Given this list of marker genes POLR2C, POLR2J, POLR2F, POLR2A, POLR2H, PTBP1, HNRNPA1, POLR2L, HNRNPF, HNRNPH1, POLR2D, POLR2K, POLR2G, POLR2I, NCBP1, ESRP2, TIA1, RBFOX2, POLR2E, ESRP1, FGFR2c, TIAL1, POLR2B, GTF2F1, HNRNPM, FGFR2b, NCBP2, GTF2F2, here is a description of the gene set: part of: Signaling by FGFR2 Reactome Pathway: FGFR2 alternative splicing studied in species Homo sapiens Alternative splicing of the FGFR2 nascent mRNA generates an epithelial specific isoform (FGFR2 IIIb) and a mesenchymal specific isoform (FGFR2 IIIc). The inclusion of exon 8 in FGFR2 IIIb or exon 9 in FGFR2 IIIc alters the C-terminal half of the D3 loop of the receptor and is responsible for the different ligand-binding specificities of the two isoforms. In recent years, a number of cis- and trans-acting elements have been identified that regulate the alternative splicing event. Exon IIIb repression is mediated by the presence of weak splice sites flanking the exon, an exonic silencing sequence (ESS) within the IIIb exon and both intronic silencing sequences (ISS) upstream and downstream. Binding of hnRNPA1, PTB1, SR family proteins and other factors to these elements represses the IIIb exon and promotes FGFR2 IIIc expression in mesenchymal cells (Del Gatto-Konczak et al, 1999; Carstens et al, 2000; Wagner et al, 2005; Wagner and Garcia-Blanco, 2001; Wagner and Garcia-Blanco, 2002). In epithelial cells, recruitment of epithelial specific factors shifts the splicing events to favour inclusion of exon 8. ESPN1 and ESPN2 are epithelial-specific factors that bind to an ISE/ISS-3 (intronic splicing enhancer/intronic splicing silencer-3) region within intron 8 to promote FGFR2 IIIb-specific splicing. A complex of RBFOX2, hnRNPH1 and hnRNPF also contribute to epithelial-specific splicing by competing for binding to a site that is occupied by the SR proteins ASF/SF2 in mesenchymal cells. Other proteins and sequences have also been identified that appear to contribute to the regulated expression of FGFR2b and FGFR2c, but the full details of the alternative splicing event remain to be worked out.